Given this list of marker genes Cldn8, Tcf12, Tdh, Sntg1, Cbr2, Fam210a, Sspn (sarcospan), Nkapd1, Spesp1, Ldah, Cadm2, Parp8, Sp1, Tnfsf4, Dennd1b, Syne1, Kctd5, Tex55, Ric3, Ldlrad3, Six1, Timm8a1, Stox2, Fnbp1l, Sub1, Gmfb, Dmxl1, Tmcc1, Rab5a, Arhgap15, Rexo5, Zfp518a, Shisa6, Ddt, Mtmr10, Sema5a, Kat2b, Ifi204, Acvrl1, Marveld1 (NCBI Gene Id 277010), Pcgf6, Itprid2, Ahcyl, Pde3b, Gdpd1, Arih1, Phf6, Cdkn2c, Kif5b, Rffl, Sh2d1b1, Fmnl2, Mbnl2, Ablim2, Ywhaz, Rnf149, Pou3f3, Tmem47, Bmp2k, Mpzl2, Lsm8 (LSM8 homolog, U6 small nuclear RNA associated), Arhgef12, Ankfy1, Slc2a2, Dnaaf5, Arl8b, Pak2, Eprs1, Gpc6, Bpnt1, Il1rap, Ngly1, Nodal, Rnf170, Rbm28, Pdzrn3, Nap1l1, Ankrd44, Dido1, Zc3h18, Chsy1, Marchf7, Rab12, Lypd6, Alcam, Ago1, Rab3c, Kcnc2, Eaf1 (ELL associated factor 1), Meiob, Syt6, Tmtc1, Rad51c, Map4k4, Slk (NCBI Gene Id 50513), Ube2w, Clvs2, Nup153, Patl2, Bmi1, Luc7l2, Cd209e, Synj2, Atg3, Dag1, here is a description of the gene set: Genes predicted to be targets of miRBase v22 microRNA mmu_miR_1948_3p in miRDB v6.0 with MirTarget v4 prediction scores > 80 (high confidence targets). species: Mus musculus Mouse Gene Set: MIR_1948_3P from publication Chen Y, Wang X (PMID 31504780)